Given this list of marker genes Fadd, Ripk1 (receptor (TNFRSF)-interacting serine-threonine kinase 1), Ripk3, Tnf, Fasl, Fas, Tlr3, Mlkl, here is a description of the gene set: The series of molecular signals which triggers the necroptotic death of a cell. The pathway starts with reception of a signal, is characterized by activation of receptor-interacting serine/threonine-protein kinase 1 and/or 3 (RIPK1/3, also called RIP1/3), and ends when the execution phase of necroptosis is triggered. Mouse Gene Set: GOBP_NECROPTOTIC_SIGNALING_PATHWAY species: Mus musculus